Given this list of marker genes SUPT7L, AVEN, GKN1, SMPDL3A, IFI44, NCF4, VAMP5, C16orf54, IKZF4, TNFAIP8L2, ATP1B3 (ATPase Na+/K+ transporting subunit beta 3), NXPE3, HDAC4 (NCBI Gene Id 9759), BCL3, CISH, SUN1, CMPK2, TLR1, PCED1B, THY1, TMIE, GPR19, DSE, CTSS, RHBDD3, SGK1, UBXN11, FAM131B, CISD3, GPRIN1, TMEM71, MS4A15, TSC22D3, IFI27L2, IGFBP4, SMAD7, KLHDC2, ESYT1, IL15RA (NCBI Gene Id 3601), EML6, PELI2, CKAP2L, SIDT1, ITGB7, USP18, PSMB9, TRAF5, PTPN22, SLC66A3, ITGB5, PSME1, ABHD15, ABCA2, PRELID2, DRC1, CDC42BPB, PSPH, GM2A, TIMP2, GSKIP, RNF207, PSME2, GGACT, CD7, LRRIQ4, TMEM64, IL2RB, CGAS, B2M, LGALS1, EPSTI1, CRMP1, ANTKMT (adenine nucleotide translocase lysine methyltransferase), STING1, PIM1, KDM7A (NCBI Gene Id 80853), E2F2, SYT11, SOX6, MAN1C1, VIPR1, HVCN1, REXO2, CRYBG2, B4GALT5, IFI30, TMCO4, ADGRE5, CHP2, MEFV, SLFN13, MTHFD1L, ENTPD5 (NCBI Gene Id 957), SFXN3 (sideroflexin 3), RFC2, FOXN2, LATS2, SLBP, ORAI3, SEMA4F, DIPK1A, FAM174B, TAGLN2, TRAPPC2B, CTSW, ENPP1, RNH1, IRF9, NXT2, BMERB1, SELPLG, SERINC3, AMIGO2, PDLIM4, ST8SIA3, PIM2, SELENOH, SOCS3 (NCBI Gene Id 9021), OAS1, GABRR2, TRAF3IP2, KCTD2, RNF213, IGFLR1, FXYD5, IRGM, POLE2, PDE3A, RFLNB, IL6R, ELF1, NDRG3, IFIT1, PKP3, CACNA2D1, LRATD2, PTPN1, PEPD, IFNGR1, PRR13, IL36RN, PTS, SORL1, ARL2BP, TPST2, C19orf38 (chromosome 19 open reading frame 38), DPY19L1, MIF4GD, NOD1, CENPM, RAD51, MID1IP1, CHST12, KLF3, SCAMP3, ABTB3, TRMO, MYC, S1PR4, HSH2D, GALNT16, SH3BP5, IFIH1, NCMAP, TNFRSF14, SYNGR2, TFAP2D, LRR1, APOBR, NECAB3, CASP7, CAPG, KBTBD11, CNP, FCER1G, IL27RA, PELI1, MSN, INF2, S1PR1, SYCE2, DENND2C, ST8SIA6, MS4A6A, STAT3, OIP5, RHCG, APPL2, RCN1, BHLHE40, NINJ2 (NCBI Gene Id 4815), PRKAR2A, TYMS, MYO10, DTD2, TXNIP, FRMD8, RIPOR2, OAS3, SKI, here is a description of the gene set: studied in species Homo sapiens Human Gene Set: GSE40443_INDUCED_VS_TOTAL_TREG_DN from publication Weiss JM, Bilate AM, Gobert M, Ding Y, Curotto de Lafaille MA, Parkhurst CN, Xiong H, Dolpady J, Frey AB, Ruocco MG, Yang Y, Floess S, Huehn J, Oh S, Li MO, Niec RE, Rudensky AY, Dustin ML, Littman DR, Lafaille JJ (PMID 22966001) iTreg cells from Tbmc mLN mice treated with one week of 1% Oral Ova were compared to Total Treg from WT mice. Genes down-regulated in T reg: induced versus total.